The following is a description of a gene set: Mouse Gene Set: GOBP_REGULATION_OF_BILE_ACID_SECRETION Any process that modulates the frequency, rate or extent of the controlled release of bile acid from a cell or a tissue. studied in species Mus musculus, and this is the list of marker genes: Abcb11, Ces1d, Cldn2, Ces1e (carboxylesterase 1E), Ces1a, Ces1f, Ces1h, Ces1g, Ces1c, Tnf, Ces1b